The following is a description of a gene set: Any process that modulates the frequency, rate, or extent of the production of molecular mediator of immune response. studied in species Mus musculus Mouse Gene Set: GOBP_REGULATION_OF_PRODUCTION_OF_MOLECULAR_MEDIATOR_OF_IMMUNE_RESPONSE, and this is the list of marker genes: Vpreb3, Cd55b, Zpbp2, Il21, Cd40lg, Xcl1 (chemokine (C motif) ligand 1), Clcf1, Spon2, Phb2, Hk1, Acp5, Cd22, Il17f, Dnajb9, Tek, Tmbim6, Foxp3, Cd55, Ffar3, Smad7, Shld1, Pagr1a, Ivl, Cd81, Cd160, Tlr7, Cd96, Il27ra, Ptprc, Bst2, Cgas, Apoa2, Gpi1, Hmox1, Shld2, Prg2, Il1b, Trim6, Klk7, Gimap5, Foxp1, Nlrp3, Il13, Htr2a, Siglecg, Kmt5c, Apoa1 (apolipoprotein A-I), Tirap, Ppl (periplakin), Clnk, Panx1, Exosc6, Il17a, Tnfaip3, Hpx, Mir181b-2, Pkn1, Lilrb4b, Litaf, Atg9a, Prkdc, Cd28, Xbp1, Ptpn22, Arid5a, Tril, Il1r1, Il18, Prkcz, Rsad2, Klrh1, Kit, Ccr2, Il13ra1, Btk, Hfe, Cd37, Slamf1, Ephb2, Mif, Pgc, Gimap3, Card9 (caspase recruitment domain family, member 9), Nr4a3, Cd226, Nsd2, Exosc3, Casp1, Stat6, Cd86, Vsir, Calhm6, Twist2, 6030468B19Rik, Nod2, Plcg2, Malt1, Ddx1, Ddx21, Il2, Tnfrsf1b (NCBI Gene Id 21938), Irak3, Psg22, Casp4, Ffar2 (NCBI Gene Id 233079), Il33, Atg5, Kmt5b, Laptm5, Scimp, Wnt5a, Rbp4, Lilrb4a, Ndfip1, Ighm, Mlh1, Il6, Stx4a (NCBI Gene Id 20909), Fcgr2b (Fc receptor, IgG, low affinity IIb), Mir324, Dennd1b, Il10, Twist1, Aplf, Bcl6, Supt6, Ube2j1, Sphk2, B2m, BC037156, Galnt2, H2-M3, Tgfb2, Il2rg, Ifnb1, Tnfrsf4, Tnf, Mavs, Trex1, Parp3, Jak3, Tgfb3, Sema7a, F2rl1, Pms2, Sash3, Mad2l2, Ccl20, Pkp3, Cd74, Map3k7, H2-T23, Tlr4, Fcer1g, Cuedc2, Sirt1, Slc15a4, Tnfsf13, Shld3, Dhx36, Gata3, Il13ra2, Ticam1, Tlr3, Myd88, Tlr2, Tnfsf4, Epx, Cd244a, Rigi, Paxip1, Mir181b-1, Inava, Mapkapk2, Il5, Tnfrsf14, Syk, Il18r1 (NCBI Gene Id 16182), Rif1, Trpm4, Nod1, Ripk2, Gprc5b, Il4, Mzb1, Traf6, Lacc1, Cd27, Trp53bp1, Tfrc, Irf5, Arg1, Cd36, Evpl (envoplakin), Clec7a, P2rx7, Tgfb1, Pycard, Ifng, Traf2, Axl, Fzd5, Nlrx1 (NCBI Gene Id 270151), Il4ra, Klk5, Phb1, Rabgef1, Rtn4, Hmces, Atad5, Angpt1, Tlr9, Msh2, Cd40, Tbx21, Fcer1a